The following is a description of a gene set: Mouse Gene Set: CUI_B_CELL_41BBL_RESPONSE_UP Genes positively differentially expressed in cell type: B cell upon treatment with cytokine: 4-1BBL in mouse lymph nodes in vivo. from publication Cui A, Huang T, Li S, Ma A, Pérez JL, Sander C, Keskin DB, Wu CJ, Fraenkel E, Hacohen N (PMID 38057668) Cytokines mediate cell-cell communication in the immune system and represent important therapeutic targets. A myriad of studies have highlighted their central role in immune function, yet we lack a global view of the cellular responses of each immune cell type to each cytokine. To address this gap, the authors created the Immune Dictionary, a compendium of single-cell transcriptomic profiles of more than 17 immune cell types in response to each of 86 cytokines (>1,400 cytokine-cell type combinations) in mouse lymph nodes in vivo. A cytokine-centric view of the dictionary revealed that most cytokines induce highly cell-type-specific responses. For example, the inflammatory cytokine interleukin-1β induces distinct gene programmes in almost every cell type. A cell-type-centric view of the dictionary identified more than 66 cytokine-driven cellular polarization states across immune cell types, including previously uncharacterized states such as an interleukin-18-induced polyfunctional natural killer cell state. species: Mus musculus, and this is the list of marker genes: Ptges2 (prostaglandin E synthase 2), Commd2, Pus7l, Itsn2, Ccdc77, Tmsb10, Sephs2, Snx32, Idua, Ipmk, Tasor2, Mib2, Mycbp, Sfxn3, Pgam1